The following is a description of a gene set: Any process that activates or increases the rate of progression from anaphase/telophase (high mitotic CDK activity) to G1 (low mitotic CDK activity). species: Homo sapiens Human Gene Set: GOBP_POSITIVE_REGULATION_OF_EXIT_FROM_MITOSIS, and this is the list of marker genes: CDCA5, UBE2C, TGFB1, NEUROG1, BIRC5